Given this list of marker genes ABCB6, STMP1, WASF1, SLC44A1, BCL2, PTGS2, NUCB2, PPP1CC, BOK, MTOR, MGARP, BAK1, ACSL3, NEU4, PPP1R15A, HADHB, CHCHD3, GK, EMD, SLC22A3, ANGEL1, MOAP1, BMF, FUNDC1 (FUN14 domain containing 1), TSPO2, THG1L, ACSL6, FATE1, CLMN, SPATA19, RHOT2, ARMC10, ATF2, RAB11FIP5, BNIP3L, QTRT2, ZNFX1, IMMT, PMAIP1, VPS13A, NAV3, BNIP1, ACSL1, CPT1B, HINT2, ITPR3, TIGAR, BPHL, KMO, LPIN1, ARMCX3, SH3GLB1, PINK1, MICOS10, SLC8A3, DHCR7, APOOL (NCBI Gene Id 139322), MIEF1, RPS6KB1, EXD2, ULK1, PSEN1, GHRHR, ATAD1, AKAP1, KASH5, SLC24A1, MICOS13, TOMM6, ARMC1, IFI6, MAPKAP1, DCAKD (NCBI Gene Id 79877), UBB, CNR1, HK1, SNCA, VDAC1, QTRT1, DNAJC11, TRABD, MYOC, ASS1, TOMM20, TUFM, ENO1, MCL1, PLD6, USP30, FUNDC2, PPP2R2B, MYO19, C11orf65, MGST1, ACSL5, SERAC1, DNM1L, EPHA4, TOMM20L, AIFM2, SYNE1, MTX1, GRK2, RETSAT, FBXL4, LETMD1, LRRK2, BBC3, SPART, SFXN2, ARMC12, SPIRE1, GPAM, MTFR1L, MT3, MTX3, CHCHD6, TRAF3IP3, BAD, MFN1, SLC25A47, LTC4S, GDAP1, FIS1, MTX2, MTARC1, PLA2G2A, OPA1, RAF1, CYB5B, RPS27A, SYNE4, CYB5A, BCL2L11, RHOT1, SLC29A3, SMIM26, APOO, DELE1, VPS13C, ARMCX2, RMDN3, SAMM50, BRI3BP, AGPAT4, RAB32, BAX, MUL1, BID, COX14, GK2, HSPA9, RNF185, SMPD4, HK2, BCL2L1, MTARC2, SEPTIN4, PTRH2, MFF, LRPPRC, PLEC, TOMM70, MGST3, MTCH2, PPTC7, ACSL4, TMEM53, VAT1, BECN1, UBA52, FOXO3, MARCHF5, CPTP, SIGMAR1, NUTF2, SYNE3, NLRX1, PGR, BCL2L2, CYP27B1, HAX1, ARMCX6, VAMP1, DMPK, ARMCX1, PHB2 (prohibitin 2), TOMM22, SOX10, SNN, BCL2L10, MTERF3, GUCY2F, TOMM7, UGT2B28, AGPAT5, TOMM34, TMEM109, MFN2, MTCH1, PIGBOS1, CISD1, TRAPPC2B, TRIM14 (tripartite motif containing 14), TAFAZZIN, AMBRA1, MIGA1, STING1, MAOB, NIPSNAP2 (nipsnap homolog 2), CASP8, PGRMC1, PRNP, MIEF2, COASY, CYB5R3, SLC25A46, MAVS, SARM1, SYNJ2BP, PDE2A, SLC11A2, RHOD, DAO, ANKH, RSAD2, SYNE2, ACACB, BCL2A1, VDAC2, CPT1A, TOMM5, MISFA, SLC44A2, UFL1, MLXIP, UBC, CISD2, GUCY2D, VDAC3, NME3, RTN4IP1, SPATA18, GPAT2, KRAS, IFI27, PRKN, TSPO, MIGA2, PGAM5, MSTO1, AGK, MAOA, ITPRIP, PI4KB, BNIP3, TOMM40, STARD7, TOMM40L, HMOX1, FAM210B, RAC2, here is a description of the gene set: species: Homo sapiens The external membrane of Gram-negative bacteria or certain organelles such as mitochondria and chloroplasts; freely permeable to most ions and metabolites. Human Gene Set: GOCC_OUTER_MEMBRANE